The following is a description of a gene set: from publication Hay SB, Ferchen K, Chetal K, Grimes HL, Salomonis N (PMID 30243574) studied in species Homo sapiens Human Gene Set: HAY_BONE_MARROW_CD34_POS_EO_B_MAST, and this is the list of marker genes: CDK15, TPSAB1, EPX, CLC, PRG2, NOX3, DTWD2, HPGD, CLEC4OP, ADCYAP1, LINC00323, LMO4, MS4A3, HDC, EXD3, TPSB2, MS4A2, SLC45A3, HPGDS